The following is a description of a gene set: Dyspnea Human Gene Set: HP_DYSPNEA Difficult or labored breathing. Dyspnea is a subjective feeling only the patient can rate, e.g., on a Borg scale. species: Homo sapiens, and this is the list of marker genes: HACE1, KCNJ3, LRP4, TBC1D24, TINF2, MYBPC3, SERPING1, RAF1, KRT6B, FHL2, TAF15, PMM2, ACADM (acyl-CoA dehydrogenase medium chain), PLCB4, ATP13A3, MAPT, GATAD1, ETFB, B2M, MRPL3, SRP54, MYH11, GTPBP3, PLN, ENPP1 (NCBI Gene Id 5167), CHRNB1, CHRNE, CRYAB, KCNQ1, KLHL24, ABCG5, SPP1, PPP1R21, GET3, RNF13, STX16, SMC5, GMNN, NEXN, TREM2, HLA-B, ACTC1, TK2, CREBBP, COL2A1 (collagen type II alpha 1 chain), IL6ST, DNAJB4 (DnaJ heat shock protein family (Hsp40) member B4), ACVRL1, LAMC2, PIGA, PSAP, ALMS1 (ALMS1 centrosome and basal body associated protein), PCSK9, NKX2-1, LDLRAP1, DPM1, LDB3, GALC, MYZAP, FIP1L1, NKX2-6, APOA1, CCR6, HLA-DRB1, SMAD4, TRMT5, MGME1, PRKCSH (NCBI Gene Id 5589), TBK1, IFIH1, SSR4, UBA1, SCN4B, MT-TW (NCBI Gene Id 4578), NDUFA8, REST, DNASE1L3 (NCBI Gene Id 1776), SNRPN, IFT81, NUP155, CACNA1A, MMUT, COL25A1, RPS28, PRRT2, MMACHC, TRPM4, ETFDH, TRIP11, ADNP, FOXE3, DNAJC21, CDC45, ATP5F1A, RNU4ATAC, CLPB, ATP1A2, RPS26, ANXA11, ITGA3, CASR, FZR1, CCN2, SGCD, PUF60, CSPP1, MATR3, ANKRD1, KCNJ2, EPOR, PSEN2, VCL, TNNC1, WIPF1, SIK1, ALG12, PRKAR1A, TWNK, SCN4A, LIFR, IFT52 (intraflagellar transport 52), RAP1GDS1, DBH, PRRX1, TRPV6, GLA, GYG1, MT-ATP6, MYT1L, DSG2, VAMP1, PON2, ETFA, TCAP, XPNPEP2, ALAS2, PON3, KRT16, CLCNKB, MT-ND6, MYL2, ZBTB16, GJA5, DPM2, BAP1, FBN1, LMNA, ATP11A, SH2B3, BAG3, FGFR2, RAPSN, BMPR2, DIS3L2, GATA5, GATA6, PIGT, PYGM, MT-TN, GNAI3, ARX, MAT2A, CFTR, KIF20A, SCN3B (NCBI Gene Id 55800), TET2, SOX9, MT-TV, MEGF10, SETBP1 (NCBI Gene Id 284262), SLC31A1, DMD (NCBI Gene Id 548327), BCOR, CFAP410, TGFB2 (transforming growth factor beta 2), TGFB3, PPARGC1A, TGFBR1, STN1, VPS33A, SLC52A3, CSF2RA, CDT1, IRF2BP2, FOXF1, COLQ (NCBI Gene Id 8292), FGFR1, DYNC2LI1, RPL3L, TGFBR2, SLC22A5 (NCBI Gene Id 6584), LOX, MYL3, ERBB4, COX7B, SCYL2, DNAJB6, KCNJ6, LTBP3, SFTPC, LDLR, YARS2, NEK1, ACADVL, ABCG8, NEMF, NEB, EFTUD2, TAFAZZIN, COL4A6, TAF1A, TTN, DAO, LMOD2, NDE1, SMAD2, PRKAG2, TBL1XR1, PFN1, POMT1, TNNT2, KLHL7, MYH6, LIN28B, MTM1, DCTN1, EIF2AK4, DPP9, SOD1, BMPER, COL4A5, ALK, LMO1, MPV17, RARA, FUS, OTX2, GATA4, MYLK, SLC34A2, BTD, HCCS, ABCC9, IKZF1, KATNB1, ORC4, HNRNPA1 (NCBI Gene Id 780920), MT-TK, B3GALT6, LRP5, SCO2, ISCU, IDH1, TLL1, DHX16, NKX2-5, SEC63, SFTPA1, ANG, SLC18A3, MARS1, AGR2, FLNC, FKTN, TPM1, MT-TE, DSP, KCNA1, SCNN1G, SERPINA1, KAT6A, MPC1, SUCLG1, SCNN1B, IRAK1 (NCBI Gene Id 3654), FDX2, GPC3, LGI4, POLG2, RRM2B, PRDM16, TFAM, PURA, STAT4, RUNX2, AGRN, AIFM1, ACTN2, PIEZO2, KRT6A, MYL4, PRKG1, CSF2RB, HEY2 (NCBI Gene Id 30830), LAMB2, STT3B, ATP6V1B2 (ATPase H+ transporting V1 subunit B2), NPPA, H19, GLT8D1, TSFM, SLC25A4, TSC2, SFTPA2, SMARCAL1, ORC6, DNAAF3, CYB5R3, COL1A2, POLG, IL1RN, HLA-DPB1, STAT5B, IFNG, TRAK1, KCNE2, MT-TL1, GNAS, SCN1B, PNPLA2, EP300, LAMA3, ZFPM2, CHAT, GAA, SURF1, EPHB4, TMPO, IRF5, TFG, MFAP5, DES, ATRX, EDA, ABCA3, GLE1, SFTPB, ABCC6, DMPK, BOLA3, SCN5A, VEZF1, MUC5B, HMGCR, TP73, SBDS, MUSK, HLCS, NUP214, FGFR3, WT1, MYH7, CHMP2B (charged multivesicular body protein 2B), CNTNAP1, PON1, LRP12, TRIM28, COA8, ZMPSTE24, PARN, ADCY6, SLC12A3, CSRP3, FLNA, DNA2, SNAP25, MYO9A, ELN, ZIC3, REEP1, SLC5A7, KRT17, PRPH, BRCA2, SMAD3, NDUFB11, WAS, SERPINH1, TNNI3, POT1, FAM13A, CCNF, MMAA, MOGS, SLC2A10 (solute carrier family 2 member 10), KCNE1, MYPN, EOMES, MT-ND2, PML, TRIP13, HBB, MMAB, FAM20C, TUBB4A, PLEC, ERF, THSD4, SLC25A1, MLX, OPTN (NCBI Gene Id 337928), CAV1, MTR, PGM1, DSC2, ATXN2, ASAH1, CITED2, TXNRD2, MYOZ2, FBP1, SMPD1, IL12B, VCP, TARDBP, USP9X, MT-ND3, NPM1, UBQLN2, ATP5MK, PPCS, ATP1A3, WDR45B, NAGS (N-acetylglutamate synthase), MT-ATP8, MT-ND1, SDCCAG8, ACTA2, NUMA1, MT-ND5, SLC1A3, RELN, NGLY1, MGAT2, PITX2, SLC35A1, UNC13A, CHRND, TMEM126B, FIG4, DOK7, NABP1, APOB, EDN1, CYB5A, KCNA5, NEFH, BAG5, PKP2, COPA, IPO8, MT-ND4, SCN2B, ACTA1, LYRM4, SAT1, TERT, UBE3B, KCNJ5, CAPNS1, SYT2, CHRNA1 (NCBI Gene Id 1134), COL13A1, SLC25A3, PSEN1, SCNN1A, ERGIC1, SQSTM1, JAK2, RBM20, COQ7 (NCBI Gene Id 51672), VAPB, DOLK, CRLF1, LAMA4 (NCBI Gene Id 3910), CHCHD10, GBA1, CAP2, ACADS, CDC6, KIT, GOSR2, TBX20, POU6F2, TSC1, ATPAF2, TPI1, NOD2, HAND2, ATP5F1E (ATP synthase F1 subunit epsilon), AK9, BANF1, JPH2, ORC1, ENG, BTNL2, TRMU, ADAMTS13, PHOX2B, LAMB3 (laminin subunit beta 3), MYCN, STAT3, ATP5F1D, PNKD, SDHA, TBX4, LONP1, FOXP3, RTEL1, TERC